The following is a description of a gene set: studied in species Mus musculus Mouse Gene Set: GOCC_GOLGI_CIS_CISTERNA The Golgi cisterna closest to the endoplasmic reticulum; the first processing compartment through which proteins pass after export from the ER., and this is the list of marker genes: Slc30a5, Tmem59, Slc30a7, Golga5, Lyz1, Atl1, Llgl1, Xylt1, Necab3 (N-terminal EF-hand calcium binding protein 3), Golt1a, Golga2, Lyz2, Bet1, Nsg2, Smpd3